Given this list of marker genes PROM1 (NCBI Gene Id 9634), BLNK (NCBI Gene Id 29760), LTBP3, NR4A2, MEF2C, PRR16, SOCS2, IRF7, KCNA5, FHL1, SLC2A3, ADGRG6, MMRN1, ATF3, COBLL1, PCDH9, SLC38A1, ATP10A, BHLHE41, DPP4, IGHM, SPAG6, BMI1, PCDHGC3, KIF17, JUN, TRPS1, MECOM, SPIB, here is a description of the gene set: species: Homo sapiens Human Gene Set: VALK_AML_CLUSTER_1 BACKGROUND: In patients with acute myeloid leukemia (AML) a combination of methods must be used to classify the disease, make therapeutic decisions, and determine the prognosis. However, this combined approach provides correct therapeutic and prognostic information in only 50 percent of cases. METHODS: We determined the gene-expression profiles in samples of peripheral blood or bone marrow from 285 patients with AML using Affymetrix U133A GeneChips containing approximately 13,000 unique genes or expression-signature tags. Data analyses were carried out with Omniviz, significance analysis of microarrays, and prediction analysis of microarrays software. Statistical analyses were performed to determine the prognostic significance of cases of AML with specific molecular signatures. RESULTS: Unsupervised cluster analyses identified 16 groups of patients with AML on the basis of molecular signatures. We identified the genes that defined these clusters and determined the minimal numbers of genes needed to identify prognostically important clusters with a high degree of accuracy. The clustering was driven by the presence of chromosomal lesions (e.g., t(8;21), t(15;17), and inv(16)), particular genetic mutations (CEBPA), and abnormal oncogene expression (EVI1). We identified several novel clusters, some consisting of specimens with normal karyotypes. A unique cluster with a distinctive gene-expression signature included cases of AML with a poor treatment outcome. CONCLUSIONS: Gene-expression profiling allows a comprehensive classification of AML that includes previously identified genetically defined subgroups and a novel cluster with an adverse prognosis. Top genes from cluster 1 of acute myeloid leukemia (AML) expression profile; 57% of the samples are FAB M1 subtype, 43% have 11q23 abnormalities, and 36% have up-regulated EVI1 expression. from publication Valk PJ, Verhaak RG, Beijen MA, Erpelinck CA, Barjesteh van Waalwijk van Doorn-Khosrovani S, Boer JM, Beverloo HB, Moorhouse MJ, van der Spek PJ, Löwenberg B, Delwel R (PMID 15084694)